Given this list of marker genes Ramp1, Drd2, Grm1, Gabbr2 (gamma-aminobutyric acid type B receptor subunit 2), Calcrl, Ramp2, Ramp3 (NCBI Gene Id 56089), Drd1, Gpr156, Gabbr1, Calcr (NCBI Gene Id 209117), here is a description of the gene set: Mouse Gene Set: GOCC_G_PROTEIN_COUPLED_RECEPTOR_COMPLEX studied in species Mus musculus A protein complex that contains G protein-coupled receptors.